The following is a description of a gene set: species: Mus musculus Mouse Gene Set: GOMF_NUCLEOSOMAL_DNA_BINDING Binding to the DNA portion of a nucleosome., and this is the list of marker genes: Macroh2a1 (macroH2A.1 histone), H1f0, H3f5, Hmgn5, Hmgn2, H1f9, H3f3b, Hmga2, Hmgn3, H3f3a, H1f10, Rcc1, H1f1, H1f5, H1f4, H2az1, H1f8, Hmgn1, Vrk1, H1f6, H1f2, H1f3